Given this list of marker genes Jph2, Ptpn6, Jph3, Abl1, Sri, Fkbp1b, Lhcgr, Aplnr, Myo5a, Nol3, Itgb3, Coro1a, Gpr39, Calm2, Diaph1, F2, Fkbp1a, Pde4d, Cxcl11, Chd7, Lyn, Dhrs7c, Bdkrb1, Jsrp1, Casq2, Cyba, Npsr1, Drd1, Pkd2, Gper1, Cx3cl1, Dbi, Mettl21c, Ednra, Snca, P2ry6, Hrc, Cemip, Xcl1 (chemokine (C motif) ligand 1), Casq1, Cxcl10, Ank2, Tmem38b, Il13, Camk2d, Cxcr3, Asph, Bax, Prkd1, Clec4b1, Trdn, Trpc1, F2r, Fcrl5, Ntsr1, Plcg1, Pdpk1, Dmd, Ms4a2, Thy1, Tgfb1, Capn3, Cacna1c, Hap1, Cxcl9, Ryr2, Htt, Calm3, Cd19, Ubash3b, Ptk2b, Tmem38a, Pln, Slc8a1, Akap6, Atg5, Tgfb2, Prkce, Gsto1, Lime1, Calm1, Ngf (NCBI Gene Id 18049), F2rl3, Gstm7, Selenon, here is a description of the gene set: species: Mus musculus Any process that modulates the frequency, rate or extent of the release into the cytosolic compartment of calcium ions sequestered in the endoplasmic reticulum or mitochondria. Mouse Gene Set: GOBP_REGULATION_OF_RELEASE_OF_SEQUESTERED_CALCIUM_ION_INTO_CYTOSOL